The following is a description of a gene set: Mouse Gene Set: GOCC_F_ACTIN_CAPPING_PROTEIN_COMPLEX A heterodimer consisting of alpha and beta subunits that binds to and caps the barbed ends of actin filaments, thereby regulating the polymerization of actin monomers but not severing actin filaments. studied in species Mus musculus, and this is the list of marker genes: Capzb, Capza1, Capza2, Add1, Capza3, Capza1b, Carmil2, Add2, Mtpn